Given this list of marker genes SCAF11, STRN3, PHF3, R3HDM1, MIS18A, SNX30, SSTR1, SYT4, SLC44A5, ASXL3, PCLO, APAF1, PBRM1, BACE1, TAF2, RPS3, TPD52, PLEKHA3, ANKRD28, LIMD1, CENPI, RAB23, KMT2D (lysine methyltransferase 2D), NCAM2, ESRRG, OCLN, PPM1A, PCDHA8, PCDHA12, UBTD2, ZCCHC14, PCDHA1, KPNA1, HECW2, DOCK9, AMPH, THSD4, OPN3, RFFL, PCDHA2, KCNH7, ARHGEF38, CTBS, ZNF436, DCLK1, DNAJB9, FUBP1, GABRA1, LIFR, KCNK10, ADIPOR1, MKX, SIPA1L2, BLMH, SCRN1, KIF1B, PIK3R1, C1orf52, TRPC1, SMG1, CAMSAP1, RASEF, RDX, FRAT2 (FRAT regulator of WNT signaling pathway 2), ATP1B1, ATXN3, ARMCX5, ANKRD50, CD38, HNRNPR, SNAP91, ERLIN1, PPAT, PPP1R15B, RNF145, NFXL1, RSPO3, CISD3, CAPZA1, TTC28, ARHGEF6, CLDN8, MAPK1, GPAM, TFDP2, NSUN2 (NOP2/Sun RNA methyltransferase 2), PCDHA13, RCOR1, PCDHAC2, LYPLA1, LEMD3 (NCBI Gene Id 23592), GLS, ZNF697 (NCBI Gene Id 90874), OXR1, LMO7, MICAL3, ENAH, WDR26, FEM1C, FYN, ATP7A, FBN2, ACTC1, DNAJC3, PCDHA10, CCDC47, TET3, CCP110, RALGPS2, MINPP1, EIF3L, PIK3CA, NR1D2, TMTC1, PPP6C, USP34, ZBTB20, MCM2, GBP6, CLK2, CDH8, RAB6C, RMDN2, EXOSC9, NCAPG, SEC31A, OTUD1, SCRN2, BCL2L11, HSD17B13, PHAF1 (NCBI Gene Id 80262), EPHX4, SLMAP, CH25H, LRP6, TDP2, PCDHA6, MORF4L1, MED17, VGLL4, MIDEAS, STAT3, NFAT5, PRIM2, TMEM248, PCDHA4, ABCB11, ANKRD34C, RABGEF1, MYOM2, CALML4, TBL1X, TMEM74, TNRC6C (NCBI Gene Id 57690), PPP1R2, VAX1, AKAP9, ADO, PLEKHM3, RFX7, MAP1B (NCBI Gene Id 4131), FHL1, RBMS1, SRPRA, QSER1, C2orf68, CSNK1G3, APP, REST (RE1 silencing transcription factor), OPALIN, ABCE1, TDG, ZBTB10, NUFIP2, NOTCH2NLA, RBMS3, PCDHA3, KAT2B, BCL11A, SYNPO2L, CNTN3, SLC20A2, ZNF24, SLC39A11, CDC6, HACD3, CTNND2, CIT, AGPAT4, NR4A3, SGCZ, ATP2B1, BNC2, ETNK1, TUB, PHF24, RAB9B, ZDHHC23, MTSS1, XKR6, OSER1, COL24A1, PSPH, TMEM178A, DENND1B, TRAM1, PLK4, DIP2C, FOXA2, CARMIL1, ARHGAP29, BRWD3, BIRC6, LRRTM4, NOTCH2, MAGED4B, TTC9 (tetratricopeptide repeat domain 9), PCDHAC1, XPO1, SIKE1, PCDH15, TET1, FIGN, DICER1 (dicer 1, ribonuclease III), MCM9, TIAM2, UBN1, NKAIN2, BIRC2, PLPP3, PDE1C, DUSP19, CBX1, RNF6, GRM5, SLC12A5, CLIP4 (CAP-Gly domain containing linker protein family member 4), PAIP1, MTO1, GATM, KRT36, KHSRP, HAS3, HNRNPH3, RSBN1, FOXA1, MTX2, ERC1, RNF20, ADCY3, PRSS23, PCDHA5, SUGP2, C6orf89, SNAI2, TCP10L2, CNTN1, CREB1 (cAMP responsive element binding protein 1), RAB33B, SETD3, SCN7A, UBE2H, DMD, MYOCD, GPR63, SHISA2, CHSY3, SPTSSB, ZSWIM6 (NCBI Gene Id 57688), RORA, FAM117B, BMPR2, SH3TC2, BMPR1A, UBE3C, KCNN3, ZNF704, YY1AP1, PDZK1, MYT1L, GABPB1, CACNG4, EFR3A, DDX17, N4BP2L1, SESN3, DLG2 (NCBI Gene Id 283225), FKBP1A, SRP19 (NCBI Gene Id 6728), RNF38, MAU2, NECTIN3, TCEAL5, CRISPLD2, ADAM22, XBP1, VTA1, MAGED4, PATL1, CSMD3, AFF2, PCDHA11, RLIM, ONECUT2, JAKMIP2, DCDC2, FAM220A, SLC10A7, BRD1, RBPMS2, AFG1L, MDM4, SALL1, ETS1, ELAVL1, JAZF1, RAB6D, ACTR3, USF3, PPP2R5A, TOMM20, NT5DC1, SYNJ1, TEAD1, KIAA1210, SUGT1, TERF1, C14orf132, NDN, BCL2L13, FHIP2A, BCKDHB, SYNJ2, DNMT3A, SRSF6, CREB5, SETD7, SNX3, TTN, SURF4, CTNNBIP1, APPBP2, PPM1E, SLC16A14, TMEM33, SUMF1 (NCBI Gene Id 285362), SH3GLB1, KCNA5, HDAC7, ZNF618, TMED10, PCDHA9, ACSL4, PRSS16, SATB1, GPD1L, TIAL1, DCAF12L2, SLC2A13, LAMP2, PDGFA, CSNK1G2, SLC30A4, KCNA4, DOCK4 (NCBI Gene Id 9732, dedicator of cytokinesis 4), TMEM123, SIX4, NTNG1, SSBP2, PRKAR1A, SLITRK3, EMC8, PPP2R5D, CDK6, CACNB4, LPGAT1, VCPIP1, MTDH, FRS2, ZNF850, ZNF280D, PCDH9, ZNF513, GFPT2, TTBK2, RAB3C, RBPJ, UBQLN1, ZBTB41 (NCBI Gene Id 360023), TSPAN2, CACNA1E, TASP1, DHRS2, SYT14, ADAM18, SOS2, SP2, MBNL3, FAM135A, PCDHA7, FOXK1, UHRF2 (ubiquitin like with PHD and ring finger domains 2), TMX4, CDK13, CBLN2, PCDH7, QKI, GPBP1L1, TRIM63, FAM218A, OSTC, ACTR10, INTS14, THAP6, BSG, SIAH2, PRDM16, FBXO38 (NCBI Gene Id 81545), RCAN1, JMY, USP45, PROSER2, RAC1, COMMD6, ERMP1, CRISP2, BBX, MAP3K2, NEK7, MBLAC2, PDPK1, RAP2A, ZNF148, PML, IRF2BP2 (interferon regulatory factor 2 binding protein 2), INPP5D, RAB6A, MAGEB3, HMGN3, SEMA3C, TCEAL4, VPS37C, ZNF736, CD96, ZRANB2, SEPHS1, NCOA4, SPRED1, MAP7D2, CLN5, PTAR1, here is a description of the gene set: Genes predicted to be targets of miRBase v22 microRNA hsa-miR-6835-3p in miRDB v6.0 with MirTarget v4 prediction scores > 80 (high confidence targets). studied in species Homo sapiens from publication Chen Y, Wang X (PMID 31504780) Human Gene Set: MIR6835_3P